The following is a description of a gene set: Reactome Pathway: Carboxyterminal post-translational modifications of tubulin This event has been computationally inferred from an event that has been demonstrated in another species.<p>The inference is based on the homology mapping from PANTHER. Briefly, reactions for which all involved PhysicalEntities (in input, output and catalyst) have a mapped orthologue/paralogue (for complexes at least 75% of components must have a mapping) are inferred to the other species. part of: Post-translational protein modification studied in species Mus musculus electronically inferred by orthology from the curated human pathway, and this is the list of marker genes: Tubb4a, Tuba4a, Tubb4b, Tuba8, Tuba1b, Tubal3, Ttll2, Ttll12, Ttll3, Tuba3b, Tubb2b, Ttll7, Tuba1c, Tubb6, Ttll9, Tuba1a